Given this list of marker genes Mymk (myomaker, myoblast fusion factor), 4930451I11Rik, Llcfc1, Folr2, Catsper1, Wdr54, Mymx, Lyzl4, Hyal5, Cd9 (CD9 antigen), Tpst2, Tmem95, Spam1, Spaca6, Lyzl6, Izumo1, Spaca5, Tie1, Eqtn, Frey1, Dcst2, Spaca3, Sppl2c, Adam1a, Folr1, Itga3, Dcst1, Spata46, Glipr1l1, Izumo1r, Spesp1, here is a description of the gene set: The joining of the lipid bilayer membrane that surround a cell with that of another cell, producing a single cell. Mouse Gene Set: GOBP_PLASMA_MEMBRANE_FUSION species: Mus musculus